The following is a description of a gene set: Human Gene Set: ACEVEDO_LIVER_CANCER_WITH_H3K27ME3_DN There is widespread interest in efficient characterization of differences between tumor and normal samples. Here, we show an effective methodology for genome-scale characterization of tumors. Using matched normal and tumor samples from liver cancer patients, as well as non-cancer-related normal liver tissue, we first determined changes in gene expression as monitored on RNA expression arrays. We identified several hundred mRNAs that were consistently changed in the tumor samples. To characterize the mechanisms responsible for creation of the tumor-specific transcriptome, we performed chromatin immunoprecipitation on microarray experiments to assay binding of RNA polymerase II, H3me3K27, and H3me3K9 and DNA methylation in 25,000 promoter regions. These experiments identified changes in active and silenced regions of the genome in the tumor cells. Finally, we used a virtual comparative genomic hybridization method to identify copy number alterations in the tumor samples. Through comparison of RNA polymerase II binding, chromatin structure, DNA methylation, and copy number changes, we suggest that the major contributor to creation of the liver tumor transcriptome was changes in gene copy number. species: Homo sapiens Genes whose promoters display lower levels of histone H3 trimethylation mark at K27 (H3K27me3) in hepatocellular carcinoma (HCC) compared to normal liver. from publication Acevedo LG, Bieda M, Green R, Farnham PJ (PMID 18413731), and this is the list of marker genes: OR4A15, PCDHGC4, ULK1, ANKRD36C, SCN8A, PCDHGB7, SCFD1, H4C8, RUNX1, NBPF15, SPG21, H3-7, COL18A1, NTRK3, INSM2, PCDHGA10, SERPING1, H4C12, H2AC11, BMP4 (NCBI Gene Id 652), ANKRD12, CCDC81, H2BC11, H4C16 (H4 histone 16), KCNC4, HERC2P4, PIK3C2B, LINC01002, NOMO1, FLJ36000, NUCB2, RECQL, CHST15 (NCBI Gene Id 9916), PHGDH, FAM217A, PCDHGB3, POMP, ZNF461, MKRN9P, H2BC6, OR4M2 (olfactory receptor family 4 subfamily M member 2), H4C14, ANLN, FOXJ2, ANKRD29, RCAN2, KATNAL2, POLR3H, OR10S1, FAM197Y2 (family with sequence similarity 197 Y-linked member 2), SHISA6, ALPK2, DTNA, FRG1BP (FSHD region gene 1 family member B, pseudogene), DTWD1, STK32B, OR8H2, PCDHGB6 (NCBI Gene Id 56100), LYST, H4C2 (H4 clustered histone 2), DHRS7, PCDH11Y, TREX2, TNFSF4, H2AC4, FAM89A, CMTM2, NOMO2, EIF3C (NCBI Gene Id 8663), PNCK, TEX56P, NBPF11, NBPF1, TMEM119, NPRL3, E2F7, OR10J5, PP2D1, OR4K15, SCUBE1, MRPL1, CCT8L2, PCDHGC3, NCLN, NBPF14, PLCB4, H2AC8, ACTRT1, OR5T3, KRTAP19-7, PCDHGA11, OR5L2, KIAA1143, H4C5, TMEM132C, USH1C, PCDH11X, OR4K13, CHST4, H2AC15, LAMA3 (laminin subunit alpha 3), KCNIP1, H2BC4, TP53TG3, ZFHX3, CDKN2A-AS1, CELF3, OR4K5, H4C4, APOL2, PPP1R16B (protein phosphatase 1 regulatory subunit 16B), YAP1, FAM170B, TYRO3, PROX1, PCDHGB4, ZFHX4, NOMO3, H2BC10, PDE4DIP, H2BC12, FRMPD4, RAPGEF4, IZUMO1 (izumo sperm-oocyte fusion 1), BMS1P20, BTBD3, PPP1R14A, FRG1, TTC6, ATP8A2, H4C15, KRTAP6-1, FSIP1, PCDHGA6, OR4K2, SATB2, H4C1, OR4Q3, OR4N2, H4C11, GRIK2, PDGFRB, SHISA4, NSD2, AJUBA, GRPR (gastrin releasing peptide receptor), CD44, TMEM121, H4C3, SLC6A10P, COCH, PRG4 (NCBI Gene Id 787), MBTPS2, H4C13, CHD9, GP5, PLP2, H2BC8, MORF4L2, H2AC16, H3C14, AGTR1, ZDHHC11, H4C6, ATP23, RALY, APCS, RNF185, H2AC14, TTC9, H2AC13, SLC51B, PCDHGA9, CRMP1, TUB (TUB bipartite transcription factor), PFN1P3, ACTR3BP2, KRTAP20-1, CDKN2A, OR4C16, H2BC5, ADAMTSL3, GGN, DUXAP10, H2BC7, TSPY2, SOHLH2, ANKRD42, PCDHGA8, GOLT1B, PCDHGB5, OR5D14, LGALS3, PCDHGC5, TSHZ2, GPC6, FAM227B (family with sequence similarity 227 member B), KIF15, H4C9, COL27A1, CNTRL, RBFOX1, H2AC17, IGSF3, TSPY1, H2BC17, CPLX2, TPTE2, RHPN2, MATCAP2, MTCL2, PLEKHH3, MYF6, OR4C13, HAUS7, OR4M1, H2AC12, ANKRD36B, TDH, PRPF39, NMI, PCDHGA7